Given this list of marker genes PLD6, MIEF1, YME1L1 (NCBI Gene Id 115724), PRKN, MSTO1, ZDHHC6, here is a description of the gene set: species: Homo sapiens Human Gene Set: GOBP_POSITIVE_REGULATION_OF_MITOCHONDRIAL_FUSION Any process that increases the frequency, rate or extent of merging of two or more mitochondria within a cell to form a single compartment.